The following is a description of a gene set: species: Homo sapiens Transcriptome of human HepaRG hepatocellular carcinoma liver progenitors in responses to a WNT3A-enriched microenvironment and dissection of pathways dependent on _-catenin and/or blocked by the SFRP-like Wnt inhibitor FZD8_CRD. Methods: Liver progenitor cells were incubated in a WNT-enriched microenvironment for 72hrs (200 ng/ml mouse recombinant purified Wnt3A from R&D Systems). Gene pathways dependent on downstream _-catenin were studied by _-catenin knockdown with specific siRNA. Gene pathways blocked by extracellular SFRP-like Wnt inhibitors were studied by co-incubating cells with recombinant purified FZD8_CRD (300 ng/ml, from R&D Systems). Independent culture experiments performed in triplicate include untreated cells or cells incubated with scrambled siRNA or with _-catenin-specific siRNA or with FZD8_CRD, alone or in combination with Wnt3A. from publication Mebarki S, Désert R, Sulpice L, Sicard M, Desille M, Canal F, Dubois-Pot Schneider H, Bergeat D, Turlin B, Bellaud P, Lavergne E, Le Guével R, Corlu A, Perret C, Coulouarn C, Clément B, Musso O (PMID 27191501) Human Gene Set: MEBARKI_HCC_PROGENITOR_WNT_UP_BLOCKED_BY_FZD8CRD, and this is the list of marker genes: MYL2, MRTFA, SDC3, SRPX2, CRACDL, NKD2, PRAG1 (PEAK1 related, kinase-activating pseudokinase 1), CRISPLD2, DNM3, DIP2C-AS1, LUM, LYPD1 (NCBI Gene Id 116372), CLIC3, RSPO3, FBN1, MMD, DISC1, PSTPIP2, POTEF, MAGED4B, MYH9, SLC1A3, IHH, GRK3, LAYN, WFDC3, NR2F1-AS1, NXN, PCDHB15, PDLIM7 (PDZ and LIM domain 7), ARHGEF3, BMF, IGFBP5, CHPF2, MILR1 (mast cell immunoglobulin like receptor 1), ALDH7A1, KIF26B, LINC01705, PHLDB1, HAPLN1, LEF1 (NCBI Gene Id 51176), JAG2, COL3A1, MYADM, SEMA3C, TNRC18, DPYSL3, RBM24, EPYC, SERPINE1, CENPVL3, EVI2A, MDM1, MEX3B, NAV1, STXBP6, ARHGDIB, LINC01173, NINJ2, EPHB2, STK32B, VCAN, PAMR1, COL5A2, ZNF827, CARMN, GNG4, ACTN1 (NCBI Gene Id 87), TRIM55, TYRP1, THBS2, CDCP1, TGFB2, ZNF608, NOG, SLC7A5, CORO1C, DCN, CCNG2, F3, CCR1, ST6GAL2, GOLGA8G, PI15, LCP1, PPP2R2C, PRSS23, SLC26A2, KANK1, FIBCD1, DCAF15, CYP1B1, NDRG4, RARG, EXT1, LCE1A, SPOCD1, GRAMD1A, NIFK-AS1, SH3BP4 (SH3 domain binding protein 4), PITX2, SEPTIN11, KLF7, PRICKLE2, TCOF1, MDFI, ARID3A, RDH10, POTEKP, ALDH3A1, LZTS1, DPT, TPM4, RGCC, FN1, CFAP74, IL1R1, CSPG5, FHL2, USF1, MOXD1, TMEM158, LFNG, KLHL4, CCDC3, IGF2BP3